The following is a description of a gene set: The chemical reactions and pathways involving amyloid-beta, a glycoprotein associated with Alzheimer's disease, and its precursor, amyloid precursor protein (APP). species: Mus musculus Mouse Gene Set: GOBP_AMYLOID_BETA_METABOLIC_PROCESS, and this is the list of marker genes: Cd36, Ace, Nat8b-ps, Epha4, Apoe, Lrp1 (low density lipoprotein receptor-related protein 1), Mme, Hap1, Bace1, Lrrtm3, Ncstn, Abca2, Aph1c, Trem2, Slc2a13, Rock1, Psen1 (presenilin 1), Tnf, Pin1, Ifngr1, Igf1, Nat8f1, Prnp, Dyrk1a, Nat8f7, Ide, Abcg1 (ATP binding cassette subfamily G member 1), Sorl1, Becn1, Casp3, Rps23rg1, Picalm, Clu, Gsk3a, Rela, Lrp4, Rock2, Ldlr (low density lipoprotein receptor), Chrna7, Psenen, Gga3, Psen2 (presenilin 2), Apeh, Rtn1, Rtn2, Adam10, Mgat3, Abca7, Tmed10, Ren1, Csnk1e, Unc13a, Sp1, Tmed10-ps, Ifng, Pin1rt1, Rtn3, Ntrk2 (neurotrophic tyrosine kinase, receptor, type 2), Aph1a, Spon1, Bace2, Gsap, Aph1b, Rtn4, Bin1, Efna1, Abcc1 (NCBI Gene Id 94110)